The following is a description of a gene set: Human Gene Set: chr9q22 species: Homo sapiens, and this is the list of marker genes: SPIN1, LINC00475, MIR23B, TBC1D2, ROR2, MIR2278, LINC02603, NXNL2, GALNT12, CENPP, AUH, ASPN, LINC00484, PRSS47P, DIRAS2, MTND4P15, SEPTIN7P7, ENSG00000298993, LINC02957, MIR24-1, PTMAP12, FBP1 (NCBI Gene Id 2203), PRXL2C, SPATA31C2, SEMA4D, NOL8, ENSG00000237626, ENSG00000228174, ENSG00000287187 (novel transcript), FGD3, TDRD7, ENSG00000223446 (novel transcript), NUTM2F, IARS1, CTSV, MIRLET7D, LINC01501 (long intergenic non-protein coding RNA 1501), IPPK, TGFBR1, CTSLP8, ENSG00000267026, LINC01508, SUGT1P4-STRA6LP-CCDC180, TSTD2, MTND4LP7, MT1P1, PTCH1, RNA5SP289, TMOD1, ALG2, PTMAP11, HABP4 (NCBI Gene Id 22927), TRIM14, MIR3153, LINC02937, MIR4670, ERCC6L2-AS1, STRA6LP, BARX1, ZNF782, CDC14B, ZNF484, ENSG00000224764, HSD17B3, RPL21P86, BICD2, ENSG00000303962, SLC35D2, LINC02843, ZNF322P1, RPL21P82, ZNF367, CCDC180, PA2G4P6, OR7E108P, ENSG00000287769, ENSG00000231990, ECM2, CDK20, GABBR2, MIR3910-2, XPA, FAM120A2P, MTCO3P29, KRT8P11, MIR4291, RNU2-46P, CKS2, YRDCP2, ENSG00000285706, MIR3074, RNU6-798P, BEND3P2, SEC61B, HSPE1P22, RNU6-86P, ENSG00000307536, ENSG00000287955, PAICSP2, MIR6854, MIR3651, RPS10P3, NFIL3, RN7SKP225, ERCC6L2, PARK7P2, MIR3910-1, RN7SL794P (NCBI Gene Id 106479510), RNU6-829P, IL6RP1, ZNF510, FBP2P1, RNU6-669P, NSA2P7, BARX1-DT, EIF4BP3, MTATP6P29, NUTM2G (NCBI Gene Id 441457), PTCSC2, SECISBP2, PCNPP2, PHF2, MIR27B, VN1R51P, NPAP1P9, SPTLC1, FBP2, MIRLET7F1 (microRNA let-7f-1), EEF1DP2, ANKS6, SHC3, GADD45G, ENSG00000283205, MFSD14CP, ENSG00000300428, MIR1302-8 (microRNA 1302-8), CARD19, TCEA1P1, SNX18P2, MIR548AU, MIR4290, OR7E116P (NCBI Gene Id 81361), SUGT1P4, ALOX15P2, SYK, VDAC1P11, NINJ1, HSD17B3-AS1, RNU6-1160P, OR7E31P, YRDCP1, LINC03026, ENSG00000227269, SNORA84, MIR4289, SPATA31E1, FANCC, ENSG00000275465, PCAT7, MIRLET7A1HG (NCBI Gene Id 112903833), MIR4290HG, ANP32B, CYCSP24, ENSG00000288062, SUGT1P4-STRA6LP, ZNF169, NCBP1, ELF2P3 (NCBI Gene Id 260336), COL15A1, HNRNPA1P14, ANKRD19P, OGN, RNA5SP288, NME2P3, RNU6-918P, NPAP1P7, KRT18P13, RNU6-714P, LINC03062, S1PR3, NANS, MFSD14B, RPSAP49, MTND3P23, HEMGN, TRMO, LINC00092, ADIPINT, OMD, RPL21P85, FAM120AOS, MIR6081, SPATA31B2P, FOXE1, MIRLET7A1, CORO2A, GAS2L1P2, MKRN10P, RNA5SP290 (NCBI Gene Id 100873543), PTPDC1, SPATA31C1, ANKRD18CP, AOPEP (NCBI Gene Id 84909), FAM120A, WNK2, FAM220CP, SUSD3, OR7E109P